The following is a description of a gene set: studied in species Homo sapiens Any process that modulates the frequency, rate or extent of osteoblast differentiation. Human Gene Set: GOBP_REGULATION_OF_OSTEOBLAST_DIFFERENTIATION, and this is the list of marker genes: MIR9-1, CEBPB, TWIST2, NOG, FBXO5, HAND2, MIR3648-1, SMAD5, CTNNBIP1, RUNX2, CCN4, FGFR2, MIR140, AXIN2, HDAC7, MIR93, WNT7B (Wnt family member 7B), ATRAID, MIR29B1, MIR100, CCN1 (NCBI Gene Id 3491), SKI, GLI3, NELL1, ID1, MIR18A, IL6, MIR20A, IL6ST, RORB, AREG, TWIST1 (twist family bHLH transcription factor 1), SMAD6, DDR2, ACVR1, TMEM53, GREM1, PRKACA, OSTN, LRP3, MIR205, BMP6, IGF1, IPO7, GDF10, CEBPD, MIR203A, NBR1, MIR138-1, DNAI3, ACVR2B, PTK2, SFRP2, LIMD1, TNFAIP6, SOX11, BMP2, GDPD2 (NCBI Gene Id 96453), RASSF2, PTCH1, GLI1, MEN1, FERMT2, HGF, FAM20C, TENT5A, SMAD3, TWSG1 (twisted gastrulation BMP signaling modulator 1), CEBPA, ATF4, REST, TOB1, TRPM4, VEGFC, CRIM1, LTF, WNT10B, TAOK3, MIR17, CDK6, FZD1, NPNT, MIR214, MIR27A, WWTR1, RIOX1, VEGFA, ID3, JUND, NPPC (NCBI Gene Id 4880), MIR24-1 (microRNA 24-1), IFITM1, MIR208A, PPP3CA (protein phosphatase 3 catalytic subunit alpha), SFRP1, YAP1 (NCBI Gene Id 10413), BAMBI, CLIC1, SOX9, HOXA2, MIR20B, WNT4, ERFE (erythroferrone), ILK, PRMT3, SNAI2, MIR675 (NCBI Gene Id 102724852), SUFU, IL6R, MIR125B1, BMPR1B, DDX5, BMPR1A, TNF, SMAD1, WNT3, MEF2C, CTHRC1, MIR548D1, LRP5, MIR106A, PTEN, GSK3B, IGFBP5, ACVR2A, MSX2, TMEM119, MIR30B, CITED1, PRKD1, FGF2, TCIRG1, RANBP3L, BMPR2, FGF23, MIR210, CHRD, MIR320A, MIR21, ZHX3, HEMGN, SCUBE3, BMP7, SUCO, BMP4, UCMA, JAG1, SEMA4D, NOTCH1, SMOC1, PPARG, NOCT, ID2, MIR98, TMEM64 (transmembrane protein 64), MIR200C, CTNNB1, TP63, FBN2 (NCBI Gene Id 877), FFAR4